The following is a description of a gene set: Reactome Pathway: Protein folding part of: Metabolism of proteins electronically inferred by orthology from the curated human pathway species: Mus musculus This event has been computationally inferred from an event that has been demonstrated in another species.<p>The inference is based on the homology mapping from PANTHER. Briefly, reactions for which all involved PhysicalEntities (in input, output and catalyst) have a mapped orthologue/paralogue (for complexes at least 75% of components must have a mapping) are inferred to the other species., and this is the list of marker genes: Gnb5, Cct5, Cct7, Cct6b, Gngt1, Gna14, Cct8, Gng11, Csnk2b, Gnb2, Gng4, Gng7, Gnb3, Cct2, Gng3, Gng8, Gng5, Cct6a, Gng10, Rgs6, Rgs9, Rgs7, Gngt2, Cct3